Given this list of marker genes VSIG4, CR1, MIR520B (NCBI Gene Id 574473), MIR520E, SUSD4, CFH, here is a description of the gene set: Human Gene Set: GOBP_REGULATION_OF_COMPLEMENT_ACTIVATION_ALTERNATIVE_PATHWAY Any process that modulates the frequency, rate or extent of the alternative pathway of complement activation. species: Homo sapiens